The following is a description of a gene set: studied in species Mus musculus Mouse Gene Set: GOBP_SPECIFICATION_OF_ANIMAL_ORGAN_IDENTITY The regionalization process in which the identity of an animal organ primordium is specified. Identity is considered to be the aggregate of characteristics by which a structure is recognized., and this is the list of marker genes: Robo2, Lrp2, Six1, Gdnf, Rbpj, Fgfr2, Fgf8, Foxh1, Fgfr4, Fgf3, Frs2, Hoxd11, Wnt2, Hoxa11, Spry1 (sprouty RTK signaling antagonist 1), Isl1, Dkk1, Fgfr1, Fgf2, Wnt11, Pax8, Pax2, Fgf1, Smarcd3, Ctnnb1, Mef2c, Bmp2, Ar, Pax3, Hoxc11, Wnt2b, Mesp1, Gata5, Wnt5a, Tbr1, Ext1, Fgf10, Robo1, Bmp4, Gli3, Axin2